The following is a description of a gene set: Genes positively correlated with T cell responses (expansion and contraction, not long term) in peripheral blood mononuclear cell in seniors (50-75) after exposure to Zostavax, time point 1D. Comment: (A) Network of genes for which the change in expression correlated with both expansion and contraction and therefore not with long-term outcome Human Gene Set: QI_PBMC_ZOSTAVAX_AGE_50_75YO_CORRELATED_WITH_T_CELL_RESPONSES_EXPANSION_AND_CONTRACTION_1D_NOT_INFORMATIVE_OF_LONG_TERM_RESPONSES_POSITIVE Vaccination with attenuated live varicella zoster virus (VZV) can prevent zoster reactivation, but protection is incomplete especially in an older population. To decipher the molecular mechanisms underlying variable vaccine responses, T- and B-cell responses to VZV vaccination were examined in individuals of different ages including identical twin pairs. Contrary to the induction of VZV-specific antibodies, antigen-specific T cell responses were significantly influenced by inherited factors. Diminished generation of long-lived memory T cells in older individuals was mainly caused by increased T cell loss after the peak response while the expansion of antigen-specific T cells was not affected by age. Gene expression in activated CD4 T cells at the time of the peak response identified gene modules related to cell cycle regulation and DNA repair that correlated with the contraction phase of the T cell response and consequently the generation of long-lived memory cells. These data identify cell cycle regulatory mechanisms as targets to reduce T cell attrition in a vaccine response and to improve the generation of antigen-specific T cell memory, in particular in an older population. from publication Qi Q, Cavanagh MM, Le Saux S, Wagar LE, Mackey S, Hu J, Maecker H, Swan GE, Davis MM, Dekker CL, Tian L, Weyand CM, Goronzy JJ (PMID 27764254) studied in species Homo sapiens, and this is the list of marker genes: CXCR2, CCL5 (C-C motif chemokine ligand 5), ITGB2, APOBEC3G, TSC22D3, CCR2, SIGLEC10, WAS, CX3CR1, CD14, JAK1, SELL, RXRA, STAT3, HLA-G, CYSLTR1